The following is a description of a gene set: The directed movement of RNA to a specific location. Human Gene Set: GOBP_ESTABLISHMENT_OF_RNA_LOCALIZATION species: Homo sapiens, and this is the list of marker genes: ATR, ZC3H3, NUP93, DDX39B, DDX19B, THOC7, ALKBH5, NDC1, NUP43, DHX9, SRSF7, EIF4A3, TGFBR2, PCID2, NUP35 (nucleoporin 35), SMG1, RFTN1, SMG6, ZC3H11C, UPF3B, POM121L2, RBM8A, THOC1, YBX1, XPO1, NXT1, C12orf50, NXF2B, RANBP2, SRSF3, MAGOH, GLE1, RAE1, SEH1L, KHDRBS1, NUP85, THOC2, NUP50, SRSF1, NUP155, SMG5, POM121, ENY2, NXF2, TOMM20, SLBP, KHSRP, POM121C, SSB, LRPPRC, SMG7, CHTOP, FXR1, PHAX, NXF1, NCBP1, SIDT1, ZFP36, RAN, IWS1, SIDT2, POLDIP3, HNRNPA1, RBM15B (NCBI Gene Id 29890), NUP54, THOC5, HNRNPA2B1, ALYREF, SARNP, SEC13, NUP98, PABPN1, SUPT6H, NPAP1, HHEX, CETN3, RBM33, ATM, XPOT, NSUN2, DDX19A, AKAP8L, MAGOHB, MRPL18, G3BP2, WNK1, XPO5, NXT2, IGF2BP3, MCM3AP, TERF1, UPF3A (NCBI Gene Id 95832), AGFG1, NUP133, RFTN2, RBFOX1, KIF5C, NUP107, NUP58, NXF3, YTHDC1, NUP210, NUP214, LUZP4, ZFP36L1, UPF2, IGF2BP1, NOL6, NUP205, AHCTF1, QKI, THOC3, EIF4E, NUP88 (NCBI Gene Id 4927), MX2, DDX25, ZC3H11A, POM121B, TNKS, SETD2, TOMM20L, CASC3, BICD2, CETN2 (NCBI Gene Id 812), RTRAF, DDX39A, FYTTD1, THOC6, MVP, FMR1, FLOT1, NUP160, NUP37, RANBP17, NPIPA1, CKAP5, SEM1, PEG10, FXR2, NUP188, UPF1, TPR, NEAT1, SENP2, PNPT1, NCBP3, NRDE2, NUTF2, AAAS, ARC, PARP11, IGF2BP2, NCBP2, HSF1, NXF5, NUP62, HNRNPA1L2, CPSF6, SNUPN, ATXN2, NUP153, ZC3H11B, KPNB1, NUP42, TST